Given this list of marker genes IGSF8, ZNF521, CGA, SERPING1, LY6G6C, TMEM269, GABRR2, SCN1A, ELF3, QPCTL, HOXD13, PRRG1, ADAMTSL4, PGPEP1, FNDC9, SCNN1A, KIF5A, SMTNL1, NKX1-2, LRRIQ4, DYNLRB2, FABP12, NCAN, SLC9A3, C8orf58, MIXL1, COL20A1, KITLG, SCN4B, CCDC24, CFAP119, KCTD7, TEKT5, FKBP6, PDGFA, C1orf50, ITGA2B, ATP1B2 (ATPase Na+/K+ transporting subunit beta 2), GUCA2B, HEBP1, OR2S2, CLEC2L, TNN, PALMD (palmdelphin), KLRG1, UST, SPTBN4, GFRA4, ALPK1, NKX2-3, TRMT44, HSPBAP1, SDK2, EPHX2 (NCBI Gene Id 2053), KRTAP3-1, TEX44, GFRA3, ZAR1, MYRF, IFITM5, RETN, LDHD, RYBP, CFAP53, PLEKHG3, ASPHD1, SLC26A2, NMU, RIPPLY3, EDA, CCNA1, SLC39A2, OR10AD1 (olfactory receptor family 10 subfamily AD member 1), SLC22A16, HTR3A, GLP1R, ACRV1, COPS8, DEFB4A, NRIP3, UGT2B17, PADI3, PPP1R3A, TMEM119, EPS8L2, TMOD2, LIX1, NLRP9, ZNF821, CACNA1B, ST7L, GNG4, SMR3A, C1QTNF7, SLN, GRB7, PLA2G4E, LINGO3, PLAGL1 (NCBI Gene Id 5325), ACVR1C (NCBI Gene Id 130399), COL19A1, FAM98C, ZMIZ2, HHEX, OMD, APOF, CES4A, NR1I2, ACOT1, PROC, HYAL3, KRTAP2-4, RUFY2, MIOX, BBS7, NRCAM, MVB12B, SERPIND1, ALDH1A3, CCDC89, ZYG11A (zyg-11 family member A, cell cycle regulator), UBAC2, PHLDB2, MYADML2, SEMA6C, PGAM2, LGI4, TNNT2, CBFA2T3, NME4, GSS, FAM241B, BATF2, SPNS3, LCN2, ETFDH, PKLR, FGF19, GABARAPL1, CCDC39, DOCK4, HDAC11, ESRRB, MFAP4, DIRAS2, FLRT1, DRD2, ARHGEF26, SLC12A1, NKX6-1, APCS, ZNF354A, GABRG2, SYPL2, KCNAB1, LRRC2, NOL3, ARID5B, SLC5A8, ZP2, MSMB, SNORC, SCRN1, KLK10, AGPAT1, DCBLD2, CCDC167, C3orf38, MUL1, DMRT2, SELENOV, CRAT, CTDSP1, ADGRL4, RRAGC, PROX1, PHLPP1, CRISP3, ARHGEF19, PEX5L, SERPINB8, PADI4, C16orf92, KIRREL1, NRSN1, FGA, DMRT3, KIAA0586, FOXD3, MEDAG, PIP4P1, LOX, GOLT1B, MRGPRF, NMBR, FAM167B, AGO2 (argonaute RISC catalytic component 2), NSUN7, RMND1, CACNG6, here is a description of the gene set: Genes down-regulated in monocytes: untreated versus M. tuberculosis 19 kDa lipopeptide (3h). In innate immune responses, activation of Toll-like receptors (TLRs) triggers direct antimicrobial activity against intracellular bacteria, which in murine, but not human, monocytes and macrophages is mediated principally by nitric oxide. We report here that TLR activation of human macrophages up-regulated expression of the vitamin D receptor and the vitamin D-1-hydroxylase genes, leading to induction of the antimicrobial peptide cathelicidin and killing of intracellular Mycobacterium tuberculosis. We also observed that sera from African-American individuals, known to have increased susceptibility to tuberculosis, had low 25-hydroxyvitamin D and were inefficient in supporting cathelicidin messenger RNA induction. These data support a link between TLRs and vitamin D-mediated innate immunity and suggest that differences in ability of human populations to produce vitamin D may contribute to susceptibility to microbial infection. from publication Liu PT, Stenger S, Li H, Wenzel L, Tan BH, Krutzik SR, Ochoa MT, Schauber J, Wu K, Meinken C, Kamen DL, Wagner M, Bals R, Steinmeyer A, Zügel U, Gallo RL, Eisenberg D, Hewison M, Hollis BW, Adams JS, Bloom BR, Modlin RL (PMID 16497887) Human Gene Set: GSE8921_UNSTIM_0H_VS_TLR1_2_STIM_MONOCYTE_3H_DN studied in species Homo sapiens